The following is a description of a gene set: Reactome Pathway: MET activates PTK2 signaling This event has been computationally inferred from an event that has been demonstrated in another species.<p>The inference is based on the homology mapping from PANTHER. Briefly, reactions for which all involved PhysicalEntities (in input, output and catalyst) have a mapped orthologue/paralogue (for complexes at least 75% of components must have a mapping) are inferred to the other species. part of: MET promotes cell motility species: Mus musculus electronically inferred by orthology from the curated human pathway, and this is the list of marker genes: Ptk2, Col2a1, Lama4, Col24a1, Itga3, Col11a2, Col5a3, Hgf, Itga2